The following is a description of a gene set: Genes up-regulated in comparison of peripheral blood mononuclear cells (PBMC) from TIV influenza vaccinee pre-vaccination versus those from day 7 post-vaccination. studied in species Homo sapiens from publication Nakaya HI, Wrammert J, Lee EK, Racioppi L, Marie-Kunze S, Haining WN, Means AR, Kasturi SP, Khan N, Li GM, McCausland M, Kanchan V, Kokko KE, Li S, Elbein R, Mehta AK, Aderem A, Subbarao K, Ahmed R, Pulendran B (PMID 21743478) Systems vaccinology has emerged as an interdisciplinary field that combines systems wide measurements and network and predictive modeling applied to vaccinology. Here we used the systems vaccinology approach to study the molecular mechanisms underlying the innate responses to the trivalent inactivated influenza (TIV) and live attenuated influenza (LAIV) vaccination in humans, and to identify early gene signatures that predict the magnitude of the antibody responses to influenza vaccination. Human Gene Set: GSE29614_CTRL_VS_DAY7_TIV_FLU_VACCINE_PBMC_UP, and this is the list of marker genes: FSHR, FAM182A, LINC02483, TLE6, ADAMTSL3, EDN2, RACGAP1P1, BLOC1S3, PTMS, ZDHHC2, ACVRL1, ZSCAN1, PALMD, C2CD4C, OR8G1, SIGLEC8, SPMIP6, RPL23AP53, GPX5, FUT1, CD48, FGFR3, C6orf62, GABRB1, PANX2, HOXB7, DDIT4, FGA, CLPS, MLNR, PAGE1, GDF5, SMAP1, PHACTR2-AS1, STRN3, PDE4A, CACNA2D1, SNORC, DUOX2, C7orf33, RXFP2, TOB1 (NCBI Gene Id 10140), FCN2, TRPC6, IL24, TEAD2, ACVR2B-AS1, ABT1, SLC5A4, ZNF157, DOCK2, SMCO1, MED9, HYAL2, FGF19, SSTR2, UQCC5, HS3ST6, DGCR5, DAB1, ASIC3, PER3P1, SNX7, BMP10, PRX, CYP4X1 (cytochrome P450 family 4 subfamily X member 1), SALL3, LENEP (lens epithelial protein), ADAMTS4, CELP, AIF1L, MCMDC2, MATN4, STATH, PEBP4 (NCBI Gene Id 157310), RUSC2, B3GNT3, TJP1, CLDN16, SPRR2B, UBXN10 (UBX domain protein 10), NTRK3-AS1 (NCBI Gene Id 283738), BAALC-AS1, IL11, ANGPTL1, DAP, WWC2-AS2, CSGALNACT2, SYNDIG1L (synapse differentiation inducing 1 like), A2ML1, CES5A, PTP4A1, TGIF1, PRAC1, CSNK2A2, NMD3, GJA8 (gap junction protein alpha 8), POLE4, CPQ, SOX4, GALT, AMER3, BEAN1, AIRE, KRTAP19-3, GREM2, CASC16, C1QB, LINC01095 (NCBI Gene Id 100505545), KRTAP1-3, SAG, PROCR, LINC01530 (long intergenic non-protein coding RNA 1530), GPR161, IL22RA2, PDLIM7, HOXA3, CLCN2, PITX2, TMX4, BMP2, TMEM247, ZNF408, SIGLEC6, FRMD6, ACKR2, MAN2B2, TAS2R41, BUD31, VSTM2A, C9orf163, SEMA5A, SEC24B, RAD51B, ALDH3A1, GLIS2, WNK3, USP25, LINC01968, SYF2, LCN6, DIPK2B, FLG2, CREM, PDHA2, SERPINB5, RIPPLY3, OR7E19P, MIGA1 (NCBI Gene Id 374986), IHO1, TPSB2, GAD1, PLEKHN1, PKHD1, ESPNL, AHI1-DT, RBM18, RAET1E, TMEM63B, RNF215, HAAO, CAPN8, GNLY, NBPF5P, NCOA1, ZNF576, ADAM3A, CFAP99, STK4, ELOA2, CYP4A22, FAM186B, SLC13A4, GRM4, LDHAL6A, LINC01949, PKD2L2, NXNL1, MIRLET7BHG, OR51J1, CHRM5, MOBP, PARVA, ADAMTS8 (ADAM metallopeptidase with thrombospondin type 1 motif 8), KCNK9, RNF213-AS1, COL4A5, FAM174C